The following is a description of a gene set: studied in species Homo sapiens The process in which a DNA segment is incorporated into another, usually larger, DNA molecule such as a chromosome. Human Gene Set: GOBP_DNA_INTEGRATION, and this is the list of marker genes: SETMAR, BANF1, KRBA2, SMARCB1, NYNRIN (NYN domain and retroviral integrase containing), THAP9, SCAND3, GIN1